Given this list of marker genes Myo1a, Evl, Kcne1, Stc1, Dbn1, Kcne5, Myo5a, Ryr2, Atp1a2, Pik3ca, Tnni3, Camk2d, Scn4b, Zeb2, Strit1, Myh14, Limch1, Acta2, Flna, Myo19, Gja5, Adrb1, Actn4, 3425401B19Rik (RIKEN cDNA 3425401B19 gene), Abcc9, Nos1, Bin1, Snta1, Rock1, Myh8, Tpm1, Wipf1, Frmd6, Adora1, Scn3b, Luzp1, Actc1, Myl6b, Scn1a, Cacnb2, Sgcd, Kcne3, Kcnj8, Scn2b, Myo1c, Kcnd3, Myo1b, Kcnj2, Kcnq1, Epdr1, Trpm4, Dsc2, Dlg1, Myl6, Cav1, Nedd4l, Mylk2, Myo1g, Pln, Ank2, Dsg2, Slc9a1, Pde4d, Wasl, Syne2, Gata4, Dsp, Ctnna3, Cav3, Atp2a1, Cacna1h (calcium channel, voltage-dependent, T type, alpha 1H subunit), Qki, Cacna1c, Uty, Ccdc88c, Epb41l5, Atp1a1, Pkp2, Myh10, Myo7b, Parva, Emp2, Pard3, Scn1b, Vil1, Jup, Gpd1l, Rangrf (RAN guanine nucleotide release factor), Sri, Pdpn, Shtn1, Wasf2, Kcnh2, Tnnc1, Myo9b, Was, Myo1d, Scn5a, Cacna1d, Akap9, Akap6, Rnf207, Kcnn2, Tnnt2, Fgf13, Myh6, Cacna2d1, Myh7 (myosin, heavy polypeptide 7, cardiac muscle, beta), Myh9, Myh7b, Kcnj5, Nup155, Myo1h (NCBI Gene Id 67424), Kcne4, Kcna5, Myrip, Myo6, Hcn4, Casq2, Kcne2, Atp2a2, Fxyd1, Fnbp1l, Adcy10, Sun2, Sumo1, Myo7a, Gsn, Ptger3, here is a description of the gene set: Movement of organelles or other particles along actin filaments, or sliding of actin filaments past each other, mediated by motor proteins. species: Mus musculus Mouse Gene Set: GOBP_ACTIN_FILAMENT_BASED_MOVEMENT